Given this list of marker genes Slc30a5, Slc39a11, Slc39a5, Slc39a12, Slc39a6, Slc39a4, Slc30a8, Slc30a1, Slc39a10, Slc39a8 (solute carrier family 39 (metal ion transporter), member 8), Slc39a14, here is a description of the gene set: The directed movement of zinc(2+) ions from outside of a cell, across the plasma membrane and into the cytosol. Mouse Gene Set: GOBP_ZINC_ION_IMPORT_ACROSS_PLASMA_MEMBRANE studied in species Mus musculus